The following is a description of a gene set: Human Gene Set: GSE45365_BCELL_VS_CD8_TCELL_UP Murine Cytomegalovirus (MCMV) infection leads to early activation of various immune cells, including B and T lymphocytes, before the actual initiation of antigen-specific adaptive immunity. This activation is partly driven by innate cytokines, including type I interferon (IFN), which are induced early after infection. The objective of this study was to address the role of type I IFN in shaping early/innate B and T cell responses to a primary acute viral infection. In order to decipher the specific impact of IFN-I on cell subsets, we performed a genome-wide expression analysis on WT splenic B and CD8 T lymphocytes isolated from C57BL/6 mixed bone marrow chimera mice. This study complements series GSE39555, which focused on early responses of NK cells and of the two subsets of conventional dendritic cells. studied in species Homo sapiens Genes up-regulated in B lymphocytes versus CD8 T cells., and this is the list of marker genes: RAMP2-AS1, SLC28A1, SLC16A4, BRDT, YTHDF3, ATG2B, TPTEP1, ADAMTS18, CDH19, GDF9, HES6, CUBN, MYO1C, SULT1C2, OTOGL, SLC35E1, RGMA, UNC13A, WDPCP, LVRN, LIN28A, DIP2A, HRCT1, PRKCZ, TRIM66, ZNF530, GABPB1-IT1, FXYD2, ZNF462, SPRY3, HPD, GLP1R (NCBI Gene Id 2740), LINC00299, P2RX3, PLXNA4, OGFRL1, CDH18, TLR9, GLRA3, ZDHHC2, SCMH1, ZNF252P-AS1, PRR18, ZP1 (zona pellucida glycoprotein 1), DSCAML1, SLC2A12, SGCD, NNMT, KLHL40, ENSG00000237870, LINC01095, BCL2L11, RNF183, ZNF837, MYO1D, KIF27, GCNT7, ATRX, ENSG00000261070, ZBP1, ATP2B1-AS1, ZNF620, CMBL, NOTCH2NLA, POU2F3, FSCN2, NOXA1, FANCC, COA8, MYL1, C11orf97, KASH5, MKS1, SIX1, LYVE1 (lymphatic vessel endothelial hyaluronan receptor 1), SCARNA15, PHKA1, CDR2-DT, MAGI2, LINC00494, UBQLN4, MAL2, LINC01792, TBX3, GNG13, MS4A12, SPMAP1, WAC-AS1, DCTN1-AS1, TAFA2, FGGY, TNFSF9, FSIP1, TSSK2, CCDC163 (CCDC163 homolog), DNAH3, SYNPO2, RASEF, ZNF75A, ADAM32, AK5, CYP4A22, AGTPBP1, MCHR1, GRM6, CLRN3, TINAGL1 (NCBI Gene Id 64129), E2F5, C1QTNF1-AS1, CDH17, SLC40A1, RDM1P5, CHD2, ERMN, GPR45, SLITRK2, MAGEA6, CUX2, DDX59, IDO2, MAGEB2, FAM181A, FRY, ASIC4, ZNF346, LINC01098, SPDYE1, PPP1R13B, IGSF9B, FUT3 (fucosyltransferase 3 (Lewis blood group)), LINC01904, UPF2, CNTN5, LINC00942, KCNK10, GPR63, TRIOBP, CNR1, AADAC, ZNF444, SLC35F5, C1orf53, KRTAP2-4, TMSB15B-AS1, BTNL3, TTLL2, PDE4C (phosphodiesterase 4C), IGHV7-81, MEIOC, CPNE1, AKAP5, CYREN, LAYN, APCDD1, KDM3A, TMEM150C, ZNF763, BOLL, ATP2C1, ADAM33, PCDHGA10, NHEG1, MYSM1, PELI2, UGT2B15, SNHG4, HMCN1, SOX1, THRAP3 (thyroid hormone receptor associated protein 3), SPESP1, COQ8A, CLPX, ZNF880, EVA1A, ALDH1A3, CD1E, YPEL5, DCAF6, ZNF394, PGF, TGM7, LINC01949, ZSCAN23, ANKMY1, BCAR3, BCL2L14, PMP22, SLC2A10, NTM, OR1G1